The following is a description of a gene set: species: Mus musculus Mouse Gene Set: chr5E2, and this is the list of marker genes: Stbd1, Septin11, Shroom3, Uso1, Scarb2, Cxcl11, Gm7832, Gm6450, Gm43596, Art3, Gm25521, Fam47e, Gm23031, Gm5558, U90926, Pramel33, Cdkl2, Trmt112-ps1, Sdad1, Parm1 (prostate androgen-regulated mucin-like protein 1), Kat2b-ps, Gm25290, G3bp2, Ppef2, Ccni, Gm22728, Pramel34, Gm2986, Ccdc158, Nup54, Ccng2, Thap6, Rchy1, Mir6415, Naaa, 2010109A12Rik, Odaph, Gm2673, Sowahb, Gm18118, Cxcl9, Mir1961, Gm15710, Gm22915, Gm19649, Cxcl10, Btc